The following is a description of a gene set: Mouse Gene Set: GOCC_FLOTILLIN_COMPLEX A protein complex that contains flotillin-1 and flotillin-2, and may contain associated proteins. Flotillins associate into membrane microdomains resembling caveolae. studied in species Mus musculus, and this is the list of marker genes: Ctnnd1, Flot1, Sorbs1, Flot2, Slc6a3, Cdh1, Coro1c, Ctnna1, Cbl, Ctnnb1